The following is a description of a gene set: Reactome Pathway: OTC main chain variants cause OTC deficiency Ornithine transcarbamylase catalyzes the reaction of ornithine and carbamoyl phosphate to citrulline in the mitochondrial matrix as the second step of the urea cycle. <br>OTC deficiency (OTCD) is an X-linked metabolic disorder of the urea cycle that leads to hyperammonemia, neurological complications and in the most pronounced cases, death. OTCD arises from mutations distributed across the functional domains of the protein and can present as a severe neonatal form (often affecting residues involved in catalysis or substrate binding and resulting in severely compromised enzymatic activity) or as later onset, clinically milder forms that affect surface or domain-interface residues and that retain partial enzymatic function. species: Homo sapiens part of: OTC variants cause OTC deficiency, and this is the list of marker genes: OTC